The following is a description of a gene set: Any process that activates or increases the frequency, rate or extent of alpha-beta T cell differentiation. species: Mus musculus Mouse Gene Set: GOBP_POSITIVE_REGULATION_OF_ALPHA_BETA_T_CELL_DIFFERENTIATION, and this is the list of marker genes: Nfkbid, Prkcz, Ripk2, Pnp, Lilrb4a, Syk, Nfkbiz (NCBI Gene Id 80859), Il18, Gimap5, Ap3b1, Cbfb, Gli3, Il2rg, Opa1, Ifng, Ccr7, Ccl19, Rhoa, Malt1 (MALT1 paracaspase), Foxp3, Socs1, Brd2, Il6, Shb, Itpkb, Lilrb4b, Tgfbr2, Rara, Zap70, Brd4, Irf1, Cd83, Tnfsf4, Runx1 (runt related transcription factor 1), Nkap, Nlrp3, Socs5, Il23a, Zbtb7b, Ccr2, Runx3, Ihh, H2-Ea, Ada, Gimap3, Ap3d1, Nckap1l, Klhl25, Mir326, Shh, Hlx, Il4ra, Cd1d1, Anxa1, Sash3, Ep300